Given this list of marker genes FGD5, H6PD (NCBI Gene Id 9563), KERA, FKBP14, CCDC80, ANXA1, HBB (NCBI Gene Id 3043, hemoglobin subunit beta), CFH, here is a description of the gene set: studied in species Homo sapiens from publication Gao S, Yan L, Wang R, Li J, Yong J, Zhou X, Wei Y, Wu X, Wang X, Fan X, Yan J, Zhi X, Gao Y, Guo H, Jin X, Wang W, Mao Y, Wang F, Wen L, Fu W, Ge H, Qiao J, Tang F (PMID 29802404) Human Gene Set: GAO_STOMACH_24W_C4_PARIETAL_PROGENITOR